Given this list of marker genes RPL21P104, RPL21P18, RAB11AP2, AVPR1A, PDCL3P7 (PDCL3 pseudogene 7), MON2-AS1, LINC02231, TSFM, APOOP3, GIHCG, USP15, LLPH-DT, LRIG3-DT, LDHAL6CP, RPS3P6, KRT18P60, ATP23, RPL32P26, LEMD3, MIR548Z, RNU6ATAC42P, SRGAP1, TMBIM4, RXYLT1-AS1, ENSG00000289319, RBMS1P1, MIR6759, OSBPL9P5, HELB, LINC02389, OSBPL9P4, GNS, RPSAP52, RNA5SP362, KLF17P1, RNU6-279P, TAFA2, C12orf56, LINC02388, RNU5A-7P, CTDSP2, RNU1-83P, RNU6-1009P, MIRLET7I, LLPH, DUX4L52, MIR26A2, RASSF3-DT, RNU6-595P, RNU6-1083P, TSPAN31, RASSF3, HMGA2, MIR6125, RXYLT1 (ribitol xylosyltransferase 1), RPS6P22, PABPC1P4, RPL36AP41, PPM1H, HMGA2-AS1, MIRLET7IHG, HNRNPA1P69, MSRB3, LINC02425, ATP6V1E1P3 (NCBI Gene Id 731648), GAPDHP44, EEF1AKMT3, RPL14P1, LINC01465, ENSG00000238440, ENSG00000303459, ENSG00000258231, LINC02448, MON2, LINC02454, RN7SKP166 (RN7SK pseudogene 166), CAND1, RNU4-20P, CDK4, ENSG00000279134, IRAK3, TBC1D30 (TBC1 domain family member 30), XPOT, RNU6-399P, MIR548C, LINC02403, RPL7P39, RN7SKP65, LRIG3, MSRB3-AS1, ENSG00000245651, DPY19L2, KICS2, RSL24D1P5, RPL21P103, METTL1, MIR6502, PCNPP3, OOEPP2, SNORD83, KRT8P19, RNU6-871P, MIR6074, AGAP2, CYP27B1, AGAP2-AS1, TBK1, AVIL, SLC16A7, GGTA2P, WIF1, ENSG00000237176, RNU6-166P, GRIP1, MARCHF9, RPS27P24, LINC03056, here is a description of the gene set: Human Gene Set: chr12q14 studied in species Homo sapiens